The following is a description of a gene set: Direct FOXP3 targets that exhibit consistent transcriptional behavior in hybridoma and in ex vivo T lymphocytes. from publication Marson A, Kretschmer K, Frampton GM, Jacobsen ES, Polansky JK, MacIsaac KD, Levine SS, Fraenkel E, von Boehmer H, Young RA (PMID 17237765) Human Gene Set: MARSON_FOXP3_CORE_DIRECT_TARGETS Foxp3+CD4+CD25+ regulatory T (T(reg)) cells are essential for the prevention of autoimmunity. T(reg) cells have an attenuated cytokine response to T-cell receptor stimulation, and can suppress the proliferation and effector function of neighbouring T cells. The forkhead transcription factor Foxp3 (forkhead box P3) is selectively expressed in T(reg) cells, is required for T(reg) development and function, and is sufficient to induce a T(reg) phenotype in conventional CD4+CD25- T cells. Mutations in Foxp3 cause severe, multi-organ autoimmunity in both human and mouse. FOXP3 can cooperate in a DNA-binding complex with NFAT (nuclear factor of activated T cells) to regulate the transcription of several known target genes. However, the global set of genes regulated directly by Foxp3 is not known and consequently, how this transcription factor controls the gene expression programme for T(reg) function is not understood. Here we identify Foxp3 target genes and report that many of these are key modulators of T-cell activation and function. Remarkably, the predominant, although not exclusive, effect of Foxp3 occupancy is to suppress the activation of target genes on T-cell stimulation. Foxp3 suppression of its targets appears to be crucial for the normal function of T(reg) cells, because overactive variants of some target genes are known to be associated with autoimmune disease. species: Mus musculus, and this is the list of marker genes: TGIF1, UCP2, GPR171, ZAP70, MYC, PTPN22, POU2AF1, S100A6, SLFN12, JAK2, DUSP6, TNFRSF9, IRF8, MAPRE2, IL2, NFKBID, ITK, GADD45B